The following is a description of a gene set: Any process that stops, prevents, or reduces the frequency, rate or extent of the directed movement of a neurotransmitter into, out of or within a cell, or between cells, by means of some agent such as a transporter or pore. Mouse Gene Set: GOBP_NEGATIVE_REGULATION_OF_NEUROTRANSMITTER_TRANSPORT species: Mus musculus, and this is the list of marker genes: Ppp1r9a, Ggcx, Snca, Nos1, Slc18a1, Htr6, Syt4, Gpm6b, Asic1, Prkn, Pnkd, Nf1, Slc18a2, Slc30a1